Given this list of marker genes Tigar, Trp53, Actn3, Ldha, Slc25a12, here is a description of the gene set: The anaerobic enzymatic chemical reactions and pathways resulting in the breakdown of glucose to lactate, and possibly ethanol, yielding energy in the form of adenosine triphosphate (ATP). species: Mus musculus Mouse Gene Set: GOBP_GLUCOSE_CATABOLIC_PROCESS_TO_LACTATE